The following is a description of a gene set: Heat shock factor 1 (HSF1) is a transcription factor that activates gene expression in response to a variety of stresses, including heat shock, oxidative stress, as well as inflammation and infection (Shamovsky I and Nudler E 2008; Akerfelt et al. 2010; Bjork and Sistonen 2010; Anckar and Sistonen 2011).<p>HSF1 is constitutively present in the cell. In the absence of stress HSF1 is found in both the cytoplasm and the nucleus as an inactive monomer (Sarge KD et al. 1993; Mercier PA et al. 1999; Vujanac M et al. 2005). A physical or chemical proteotoxic stress rapidly induces HSF1 activation, which occurs through a multi?step process, involving HSF1 monomer-to-homotrimer transition, nuclear accumulation, and binding to a promoter element, called the heat shock element (HSE), which leads to the increase in the stress-inducible gene expression (Sarge KD et al. 1993; Baler R et al. 1998; Sonna LA et al. 2002; Shamovsky I and Nudler E 2008; Sakurai H and Enoki Y 2010; Herbomel G et al. 2013). Depending on the type of stress stimulus, the multiple events associated with HSF1 activation might be affected differently (Holmberg CI et al 2000; Bjork and Sistonen 2010). Reactome Pathway: HSF1 activation studied in species Homo sapiens part of: Cellular response to heat stress, and this is the list of marker genes: EEF1A1, HSP90AB1, RPA1, YWHAE, HSPB1, RPA2, GML, UBB, SERPINH1, HSPH1, DNAJB1, TNFRSF21, HSF1, HSPA1L, HSBP1, COL4A6, DNAJB6, HSPA1B, HSP90AA1, HSPA6, DEDD2, HSBP2, HDAC6, HSPA1A, PTGES3, RLN1, CRYBA4, VCP, RPA3, FKBP4, HSPB2, MRPL18